Given this list of marker genes RNF5, IL17RA, GUSB, RASA2, SNF8, PNO1, GRPEL2, SUCO, UBE2V1, EIF3B, PGS1, PFKL, LAD1, SDHA, MFSD14A, KCTD1, EDEM3, GJA1, SNX18, CRTAP, BNIP1, PDGFRB, ABHD5, BRCA1, YAF2, QNG1, VDAC1, LCOR, PLPP3, MRPS14, CCT8, TRIM27, MAN1A2, GNB2, ZMYND8 (NCBI Gene Id 55497), PARVG, ATG4D, PPT2, SRP19, MSTO1, CCT3, ACP2 (NCBI Gene Id 96117), TMX1, UQCRQ, SLC4A2, KRTAP4-12, NCBP1, LSS, CDK8, HSP90AA1, TM9SF4, EPHB2, KIF21B (NCBI Gene Id 54770), CKS1B, MOB3B, STK40, NOP10, MLF2, UBE2M, GET3, TP53BP1, NNT, VPS16, STARD4, KLHL7, UBL5, DNAJB2, CANX, ELK3, EOLA1, HSD17B12, PRELID1, PHF8, PHYKPL, GABARAPL2, RABL3, EIF3E, YY1, PDCD4, PCNX3, DIABLO, RRP8, SENP2, SNRNP40, TMED7, POT1, ACO1, SRM, ABL1, MAFF, SQOR, TEX10, TTC13, ABCA4, NDUFAF4, RAMP2, TJP1, USP34, DCTN3, PAPSS1, WASHC2A, PC, DUSP2, NUDT4, MTFR1, ST7L, TARBP2, AEN (NCBI Gene Id 64782), NSFL1C, KIF3C, AP3S2, SUMO3, STIP1, CAB39L, TOP1, TM9SF3, ST7, B3GALNT1, CAMSAP1, IMP3, ABCG2, UTP11, RPP40, SACM1L, MSANTD3 (Myb/SANT DNA binding domain containing 3), RIOK2, JTB, PTGES2, ADAMTS5, EIF4H, PWP2, CYB5A, NELFB, NUP160, FCER1G, CLCN5, DDT, TRMT2A, YWHAG, DIMT1, LETMD1, BTG2, STYX, HCK, GRK2, EMILIN1, S100A1, AMPD2, MAPK8, CLOCK, TRAPPC10, NDUFA9, PRMT3, SEC61G, MND1, ZNF281, ANAPC7, NOLC1, NMD3, DHX15, GPR37L1, WDR12, CKS2, C5orf24, ATP5PF, POU2F2, FBXO33, FAM20B, SAMD8, DNAJB6, TFB1M, SLC25A26 (solute carrier family 25 member 26), PSMC5, PPP1CB, AKR1B15, GMFB, HNRNPR, LGALS12, CYFIP2, POLR2K, CCDC47, ELOVL1, IER2 (NCBI Gene Id 9592), MEFV, SCYL1, CCDC127, KATNBL1, SLC25A30, ATAD3A, CLEC4D, ARHGAP1, TF, MRPS22, TMED5, SLC6A12, MRPL54, RDX, UBE2G1, SEC11A, here is a description of the gene set: studied in species Homo sapiens mouse primary BMDCs were stimulated with tlr ligands and gene expression changes were profiled on Affymetrix arrays Human Gene Set: GSE17721_POLYIC_VS_GARDIQUIMOD_6H_BMDC_DN from publication Amit I, Garber M, Chevrier N, Leite AP, Donner Y, Eisenhaure T, Guttman M, Grenier JK, Li W, Zuk O, Schubert LA, Birditt B, Shay T, Goren A, Zhang X, Smith Z, Deering R, McDonald RC, Cabili M, Bernstein BE, Rinn JL, Meissner A, Root DE, Hacohen N, Regev A (PMID 19729616) Genes down-regulated in comparison of dendritic cells (DC) stimulated with poly(I:C) (TLR3 agonist) at 6 h versus DC cells stimulated with Gardiquimod (TLR7 agonist) at 6 h.